The following is a description of a gene set: Mouse Gene Set: WP_REGULATION_OF_CARDIAC_HYPERTROPHY_BY_MIR208 studied in species Mus musculus Regulation of cardiac hypertrophy by miR-208, and this is the list of marker genes: Mstn, Mir208b, Hopx, Myh7, Gata4, Med13, Gja5